Given this list of marker genes Arf1, Cdk5, Kcnb1, Stx1a, Zp3, Syt10, Rph3al, Cacna1h (calcium channel, voltage-dependent, T type, alpha 1H subunit), Doc2b, Syt9, Cdk5r2, Doc2a, Cadps, Scamp5, Syt1, Stxbp1, Rph3a, Doc2g, Syt4, Cacna1g, Syt7, Hyal3, Cacna1i, here is a description of the gene set: studied in species Mus musculus Any process that activates or increases the frequency, rate or extent of calcium ion-dependent exocytosis. Mouse Gene Set: GOBP_POSITIVE_REGULATION_OF_CALCIUM_ION_DEPENDENT_EXOCYTOSIS